The following is a description of a gene set: Human Gene Set: KEGG_MEDICUS_REFERENCE_STRAD_STK11_TSC_SIGNALING_PATHWAY STRAD/STK11- TSC signaling pathway. Pathway ID: N01576. Pathway type: Reference. Pathway class: nt06522 mTOR signaling. studied in species Homo sapiens Pathway Definition from KEGG: (STRADA+STRADB+STK11) -> (PRKAA1+PPKAA2) -> (TSC1+TSC2+TBC1D7), and this is the list of marker genes: PRKAA2, TSC1, TSC2, STK11, TBC1D7, STRADA, PRKAA1, STRADB